Given this list of marker genes Tmod1, Itga10, Pcdh10, Phtf2 (putative homeodomain transcription factor 2), Nrg3, Surf4, Ppm1d, Rapgef2, Nynrin, Vwa3a, Cndp1, Cnst, Prrg3, B3galnt1, Rnf4, Hnrnpul2, Myo6, Mier3, Lgalsl, Stk35, Fbxo33, Trim10, Serpina3n, Cibar2, Plekhb1, Pdap1, Bicd1 (BICD cargo adaptor 1), Capzb, Adamts6, Opa3, Pclo, Slc8a1, Slc24a3 (NCBI Gene Id 94249), Cdc42bpa, Pdzrn4, Trpm2, Clk3, Klhl2, Gpc5, 4930555G01Rik, Kbtbd4, Nfam1, Slc25a40, Vamp2, Rab8a, Cyp1a1, Adam12, Zfp704, Wwp1, Lamp3 (NCBI Gene Id 239739), Eif3f, Ncam1, Fam78a, Copg2, Mbnl1, Dgkg (diacylglycerol kinase, gamma), Noto, Ttl, Cers6, Arrb1, Palld, Spock1, Def8, Atp10a, Zbtb43, Cdh17, Ythdf3, Ier5 (NCBI Gene Id 15939), Ccny, Sel1l, Gbp7, Syn3, Plppr1, Abi1, Aplp2, Cgn, Zdhhc9, Pde2a, Prr18, Rgs7, Phc2, Uroc1, Strip2, Sp4, here is a description of the gene set: from publication Chen Y, Wang X (PMID 31504780) Mouse Gene Set: MIR_7043_3P Genes predicted to be targets of miRBase v22 microRNA mmu_miR_7043_3p in miRDB v6.0 with MirTarget v4 prediction scores > 80 (high confidence targets). species: Mus musculus